Given this list of marker genes NRP1, CNTN6, EPHA4, EFNB3, EPHB3 (EPH receptor B3), CDK5R1, CASP3, CRTAC1, EPHA3, NCAM2, IGSF9, GAP43, CNTN4, ARHGAP35, PCDH12, FOXG1, NTM, YWHAZ, EPHB2, NDN, MEGF8, DSCAML1, PLXND1, FEZF2, CNR1, CNTNAP2, DSCAM, ROBO2, EXT1, BSG, RTN4, OPCML, ROBO1, TNFRSF21, APP, SEMA5A, NRCAM, AMIGO1, PALLD, ROBO3, NPTN, NEXN, ROBO4, TNN, CNTN2 (NCBI Gene Id 6900), EMB, MYPN, here is a description of the gene set: species: Homo sapiens Human Gene Set: GOBP_NEURON_RECOGNITION The process in which a neuronal cell in a multicellular organism interprets its surroundings.